Given this list of marker genes UCK1, UCK2, CDA, UPP2, UCKL1, TK2, UPP1, here is a description of the gene set: Any process that generates a pyrimidine-containing compound, a nucleobase, nucleoside, nucleotide or nucleic acid that contains a pyrimidine base, from derivatives of them without de novo synthesis. Human Gene Set: GOBP_PYRIMIDINE_CONTAINING_COMPOUND_SALVAGE studied in species Homo sapiens